Given this list of marker genes PARK7, NOS3, KRT18, TREM1, NOS1, NCK2, GRIK2, NLGN4X, DYNLL1 (NCBI Gene Id 8655), PSAP, SCN5A, GRIA1, MAP3K7, BRAF, GRID2, P2RY1, SHANK3, ATG4B, DLG4, KRT5, MAP2K2, NLGN1, NLGN4Y, VIM, PHF6, KRT8, CD163, CHUK, KCNA5, CACNA1G, NLGN3, CRK, DLL1, SHANK1, AKAP5, CRIPT, CAV2, ADCY5, XRCC6, FYN, BAIAP2, DSP, UBTF, DYNLL2, LYN, IKBKB, CIT (citron rho-interacting serine/threonine kinase), GRM2, MAP2K1, GIT1, PLCG2, IL6ST, GRM3, PANX1, SRC, CDC37, TCOF1, ATP2B4, TREM2, KRT15, PDE4D, HSP90AA1, CASP8, MYLK, GSK3B, ITPR2, KCNH2, LRP4, SYK, KCNQ1, YWHAE, CACNA1H, here is a description of the gene set: studied in species Homo sapiens Binding to a scaffold protein. Scaffold proteins are crucial regulators of many key signaling pathways. Although not strictly defined in function, they are known to interact and/or bind with multiple members of a signaling pathway, tethering them into complexes. Human Gene Set: GOMF_SCAFFOLD_PROTEIN_BINDING